The following is a description of a gene set: species: Homo sapiens Binding to and responding, e.g. by conformational change, to changes in the cellular level of a metal ion. Human Gene Set: GOMF_METAL_ION_SENSOR_ACTIVITY, and this is the list of marker genes: SYT2, SLC39A4, SYT10, MICU2, SYT12, EFHB, SYT4, SYT1, SYT6, MICU3 (mitochondrial calcium uptake family member 3), SYT9 (synaptotagmin 9), SYT11, EFCAB9, SYT15, SYT3, SYT17, SYT13, SYT7, SYT8, SYT5, EFHD1, MICU1